The following is a description of a gene set: species: Homo sapiens Decreased time between the start of the Q wave and the end of the T wave as measured by the electrocardiogram (EKG). Human Gene Set: HP_SHORTENED_QT_INTERVAL Shortened QT interval, and this is the list of marker genes: CDC73, KCNJ2, CACNA2D1, CDKN1B, CACNA1C, CDKN2B, KCNH2, CACNB2, MEN1, CDKN2C, CDKN1A, KCNQ1, SLC4A3